Given this list of marker genes Nek10, Rap2b, Nbn, D1Pas1, Tom1l1, Rap2a (RAS related protein 2a), Tnks1bp1, Iqgap1, Ctnnd1, Mre11a, Rassf2, Prlr, Pdgfb, Vegfc, Nrg1, Rap2c, Vegfa, Ddx3x, Gpnmb, Grem1 (NCBI Gene Id 23892), Ngf, Rad50, Pdgfa, here is a description of the gene set: Mouse Gene Set: GOBP_POSITIVE_REGULATION_OF_PROTEIN_AUTOPHOSPHORYLATION Any process that activates or increases the frequency, rate or extent of the phosphorylation by a protein of one or more of its own residues. studied in species Mus musculus